Given this list of marker genes CSPG4, FABP5, NT5DC2, BMP2 (NCBI Gene Id 650), PLOD1, BMAL2, EYA1, IGF2BP2, ANKH, PLA2G4A, FERMT1, IL1R2, ICAM1, CDH19, EVA1A, NIBAN2, HORMAD1, PLAGL1, KIF14, FOXC1, G0S2, GABRA5, CYP26B1, GOLT1B, BCL2A1, TNFRSF11B, HAPLN1, ADM, HAS2, UPP1, LARP6, VIM, HRH1, COL27A1, RTL8C, S100B, PCOLCE2, FJX1 (NCBI Gene Id 24147), PTX3 (pentraxin 3), GAL, ADORA2B, BCAT1, IL6, MYC, YBX3, SRSF12, ENPP2 (NCBI Gene Id 5168), FLNA, HMOX1, P3H2, EFNB1, IGF2BP3, HYCC1, HRCT1, FOXD1, SRD5A1, TMEM158, RTEL1, FOXL2, SULT1B1, COLGALT1, COL9A1, S100A3, LINC00839, COL9A3, GNAI1, PRNP, OCA2, CXCL8 (C-X-C motif chemokine ligand 8), CTSZ, DAZL (NCBI Gene Id 1618), SOD2, TNFRSF12A, CALU, MSN, NMT2, LRRC8C, CEBPB, GPM6B, PLOD2, PDIA2, TEX12, ANGPTL4 (NCBI Gene Id 93954), here is a description of the gene set: Metaplastic carcinoma of the breast (MCB) is a poorly understood subtype of breast cancer. It is generally characterized by the coexistence of ductal carcinomatous and transdifferentiated sarcomatous components, but the underlying molecular alterations, possibly related to epithelial-mesenchymal transition (EMT), remain elusive. We performed transcriptional profiling using half-a-genome oligonucleotide microarrays to elucidate genetic profiles of MCBs and their differences to those of ductal carcinoma of breasts (DCBs) using discarded specimens of four MCBs and 34 DCBs. Unsupervised clustering disclosed distinctive expression profiles between MCBs and DCBs. Supervised analysis identified gene signatures discriminating MCBs from DCBs and between MCB subclasses. Notably, many of the discriminator genes were associated with downregulation of epithelial phenotypes and with synthesis, remodeling and adhesion of extracellular matrix, with some of them have known or inferred roles related to EMT. Importantly, several of the discriminator genes were upregulated in a mutant Snail-transfected MCF7 cell known to exhibit features of EMT, thereby indicating a crucial role for EMT in the pathogenesis of MCBs. Finally, the identification of SPARC and vimentin as poor prognostic factors reinforced the role of EMT in cancer progression. These data advance our understanding of MCB and offer clues to the molecular alterations underlying EMT. from publication Lien HC, Hsiao YH, Lin YS, Yao YT, Juan HF, Kuo WH, Hung MC, Chang KJ, Hsieh FJ (PMID 17603561) Genes up-regulated between two breast carcinoma subtypes: metaplastic (MCB) and ductal (DCB). Human Gene Set: LIEN_BREAST_CARCINOMA_METAPLASTIC_VS_DUCTAL_UP studied in species Homo sapiens